The following is a description of a gene set: A nonmotile primary cilium that is found at the apical surface of auditory receptor cells. The kinocilium is surrounded by actin-based stereocilia. studied in species Mus musculus Mouse Gene Set: GOCC_KINOCILIUM, and this is the list of marker genes: Rac1, Dcdc2a, Ift88, Rsph9, Tiam1, Grxcr1, Cdh23, Ift20, Cdc14a, Mkks, Strc (NCBI Gene Id 269343), Elmod3 (NCBI Gene Id 232089), Kncn